Given this list of marker genes HEY2, TRIM58, WNT1, GET3, IKZF1 (NCBI Gene Id 55429), ZFYVE28, TSPYL2, RAB5B, SSR2, NPTX1, CREB3L2, LTBP2, GNAO1, ZNF444, TBL1XR1, PARVA, PLEKHG6, PM20D1, PCDHAC2, PCDHA12, SREBF2, EIF1AD, YWHAE, USP36 (NCBI Gene Id 80160), DNAJC5G, RBM20, ZNF703 (NCBI Gene Id 80139), CNGA2, PEX11A, ADH6, TCHHL1, HYAL2, IER5, DLX3, SNX20, MLLT11 (MLLT11 transcription factor 7 cofactor), FNDC9, MYEOV, SSBP2, EXD2, PRKCG, KIF21B, RPH3A, PCDHA13, PRELP, PABPC1L2B, RNASE13, VGLL3, MRTFA, CDC42BPA, VTI1A, ANK1, C19orf47, MPDU1-AS1, CDR2, PPP1R13L, UBE3A, HCN4 (hyperpolarization activated cyclic nucleotide gated potassium channel 4), ETV3L, MRPL19, RAPGEFL1, ARFGEF3, NEUROD2, NAGA, ERAL1, FAM163B, LRRC27, CHRNA2, APOBEC2, DISC1, PLSCR3, SRD5A3 (steroid 5 alpha-reductase 3), SMARCC2, MLF2, CRNKL1, NR2E3, MGLL, PCDHA2 (NCBI Gene Id 56146), DNAJB1 (NCBI Gene Id 3337), MUC22, METTL25B, CHCHD3, HDAC3, SPIRE1, PRELID2, MTSS2, MARCKSL1, KDM2A, PLBD2, COL9A3, LLCFC1, ALPK3, KCNA6, TOM1L2, SIGLEC1, HIPK2, RABGAP1L, CD209, CORO1C, SCAMP5 (secretory carrier membrane protein 5), EIF1, SHISA6, CCDC97, YIPF3, PCDHA11, FAM168A, GCK, HLA-E, SLC36A1, NAIP, ATAT1, PCDHA7, CD8B, CEP120, PABPC1L2A, PCDHAC1, FIGNL2, SIX2, PLP1, TRIM66, MYCL, TP53INP2, PDE4D, FST, CCNK, BEND4, BCAM, XYLB, ASIC1, PAK1, CXCL17, USP49 (ubiquitin specific peptidase 49), PCDHA3 (NCBI Gene Id 56145), HNRNPL, ARRB1, HTR1D, MORC4, PLEC, ZNF569, EFNA1, TNFRSF10B, PPP4R1, SLC6A6, ANKRD45, TBL1X, CALU, FMNL3 (NCBI Gene Id 91010), ZCCHC4, STX6, SDC3, SLC17A7, CACNA1E, USB1, SHANK1, ZNF385A, ARHGAP24, CLASP2, CADM3, PCDHA4 (NCBI Gene Id 56144), MAP6, SLC22A23, SERPINB8, CAMK1D (calcium/calmodulin dependent protein kinase ID), KCNB1, GIGYF2, MTCL2, CASP2, EPHB2, ADARB2, PCDHA6, WNT9B, IGSF3, SCN2B (sodium voltage-gated channel beta subunit 2), STK40, RBPJL, KCNAB2, EYA3, PER1, INTS5, RNF220, TRIM38, PCDHA8, LHX2, NRM, CRIPT, SEMA4G, OPCML, HOXC6, DYNLL2, HNF1B, ARF4, SYT6, EXTL3, SMAD2, FZD4, PPFIA4, C2CD6, ITGA7, RIBC1, PCDHA5, RAPGEF1, NAPA, PCDHA1, GSK3B, EHMT2, PIP4K2C (NCBI Gene Id 79837), SNX19, PCDHA10, FOXRED2, SYP, AMT, PABIR3, PSEN1, AMER1, NDFIP1, SHISAL1, ANKH, MTHFR, RIMS4, CLCN5, HIP1, CSRNP3, SCN4B, CCDC102A, HSPB6, CD164, TFDP1, PCDHA9, ZNF407, AHCYL1, PELI1 (NCBI Gene Id 57334), LINC02801, SEC24D, ZC4H2, LDB1, here is a description of the gene set: Genes predicted to be targets of miRBase v22 microRNA hsa-miR-8085 in miRDB v6.0 with MirTarget v4 prediction scores > 80 (high confidence targets). from publication Chen Y, Wang X (PMID 31504780) Human Gene Set: MIR8085 species: Homo sapiens